The following is a description of a gene set: Mouse Gene Set: GOBP_REGULATION_OF_ANTIGEN_PROCESSING_AND_PRESENTATION_OF_PEPTIDE_ANTIGEN studied in species Mus musculus Any process that modulates the frequency, rate, or extent of antigen processing and presentation of peptide antigen., and this is the list of marker genes: Trem2, H2-Ob, Hfe, Tapbpl, Pycard, H2-Oa, Tap2